The following is a description of a gene set: Human Gene Set: GOBP_VENTRICULAR_COMPACT_MYOCARDIUM_MORPHOGENESIS species: Homo sapiens The process in which the anatomical structures of the compact cardiac ventricle muscle are generated and organized., and this is the list of marker genes: LRP2, TGFBR3, DSP, CHD7 (chromodomain helicase DNA binding protein 7), POU4F1, BMPR1A, NOG, TGFBR1